Given this list of marker genes NKX2-1, SPDEF, NFIB, GATA6, IGF1, AIMP2, FGF10, HOXA5, AGR2, IL13, ASCL1, RBBP9, here is a description of the gene set: Human Gene Set: GOBP_LUNG_SECRETORY_CELL_DIFFERENTIATION species: Homo sapiens The process in which a relatively unspecialized cell acquires specialized features of a lung secretory cell. A lung secretory cell is a specialized epithelial cell of the lung that contains large secretory granules in its apical part.